The following is a description of a gene set: from publication Gryder BE, Yohe ME, Chou HC, Zhang X, Marques J, Wachtel M, Schaefer B, Sen N, Song Y, Gualtieri A, Pomella S, Rota R, Cleveland A, Wen X, Sindiri S, Wei JS, Barr FG, Das S, Andresson T, Guha R, Lal-Nag M, Ferrer M, Shern JF, Zhao K, Thomas CJ, Khan J (PMID 28446439) Human Gene Set: GRYDER_PAX3FOXO1_TOP_ENHANCERS While previous studies have attempted to identify PAX3-FOXO1 target genes, these were based either on changes in gene expression or proximity to PAX3-FOXO1 in a single cell line with no consideration of expression or chromatin context. By gene expression many targets could be falsely identified which were in fact indirect, and 336 (31%) of the nearby genes previously reported to be direct targets were not expressed, while others may not be physically interacting because of barriers in 3D chromatin space. We therefore identified high-confidence PAX3-FOXO1 target genes by a series of criteria: first, using only PAX3-FOXO1 bound to enhancers recurrent in cell lines and tumors. Secondly, we only selected expressed genes, as PAX3-FOXO1 was not found in repressive chromatin. Third, we excluded nearby expressed genes if they were not found within the same topologically associated domain (TAD) as the PAX3-FOXO1 bound enhancer. Fourth, we also called out the maximally expressed gene within each TAD harboring PAX3-FOXO1. This approach removed 435 nearby but not expressed genes, and 78 expressed but out of TAD bounds. We found 1010 high-confidence targets, 678 of which were novel, and 439 were significantly reduced by shRNA knockdown of PAX3-FOXO1 for 48 hours. Novel targets include 24 oncogenes, 14 pan-cancer upregulated genes, 53 transcription factors, and 7 imprinted genes, many of which were rapidly decommissioned upon depletion of P3F (both reduced RNA-seq and H3K27ac at their enhancers. Expressed genes (FPKM>1) associated with super-high-confidence PAX3-FOXO1 sites with highly-recurrent enhancers in primary tumors and cell lines, restricted to those within topological domain boundaries species: Homo sapiens, and this is the list of marker genes: HSPG2 (NCBI Gene Id 7796), PRDM12, PODXL2, RPS6KC1, ZNF664, NDUFA12, ZNF331, SPSB4, BABAM1, TRIM45, CDC5L, ASS1, ATP6V1E1, TCF7L2, FIP1L1, PGF, STIM2, SEMA6A, ARHGEF10, PARN, ARHGAP26, SHB, ASB13, TNKS2, PIPOX, RAD51C, NCOA1, LRRC10B, TRAP1, ERICH1, TMCC3, ATF6, CLINT1, TTK, JARID2, PSMD8, RERE, ITGB1, NRG1, GNAS, RCN1, COX5A, TTI1, NOTCH2, PARK7, FSCN1, TFAP2B, SPRY1, PPP1R3B, HS1BP3, CSTF2T, LRPAP1, EXTL3, CTNNBL1, FUT10, HNRNPK, TGOLN2, ARL4C, INPP4B, TBX15, SDC2, FASTKD2, DDX1, TBCD, SETX, GIT2, SFXN1, MEDAG, GRB10, MLH1, RMI1, TCF12, SLC38A10, PROX1, PEMT, PNO1, PEBP1, SCARB1, GDI2, HMGXB4, RNF216, PSMB6, PCBD1, YWHAZ, EFHD2, CHST11, TCF7L1, TSC22D2, CELF2 (CUGBP Elav-like family member 2), GALNT11, DDOST, MEST, TXNRD1, GART, ACTB, TLE3, AP1B1, TNPO1, ACTG1, PTPN12, GNL3L, ALK, PARP1, VDAC3, UQCR10, RNF145, STX16, RBPJ, LAMB3, IMMT, RNF114, CPA5, DCP2, COBL (cordon-bleu WH2 repeat protein), LAPTM4A, CEBPZ, VPS4B, MAGED2, GLO1, NR3C1, MSH6, CLASP1, FBXO21, UBE2G1, ADCY9, PARD3, ACOX3 (acyl-CoA oxidase 3, pristanoyl), BCAR3, POMT2, TANK, RBM38, PRCP, NACA, ANLN, IL4R, AGPAT5, NOSIP (NCBI Gene Id 51070), SNRPD3, MAGI1, PLAAT1, N4BP2L2, IGFBPL1, CCDC3, TBC1D2B, ANKRD13A, SF3A3, ELP1, UBAC2, SAMD4A, CDK2AP1, NSMCE1, BMERB1 (bMERB domain containing 1), ESYT2, CADM2, KANK4, HDAC5, PTTG1IP, TBCA, TMEM177, FAM136A, VAX2, KANK1, CDC42EP3, PFDN4, TEX261, DMRT2, ZIM2, STK24, TOM1, PKNOX2, AOPEP, GSE1, SSU72, MRPL23, ATP5MJ, TNNT2, RRM2B, APLF, GAS1 (NCBI Gene Id 2619), WDR45B, PPM1H, COA6, RAPGEF1, SLC38A1, RAD23B, CAP1, MSI2, GDAP1, SMPDL3A, CEP128, RNF181, CDON, FOXN2, CD9, RIMKLB, RAD51B, CGRRF1, GRN, ZNF264, KCTD2, NDUFS3, NDUFAB1, OLIG2, ECT2, TMBIM4, SDC1, CAND1, TUT7, ITPKB, ARHGEF3, ALDH1A3 (aldehyde dehydrogenase 1 family member A3), PEG3, CNOT2, POR, ZEB2, DDB1 (NCBI Gene Id 1642), ATOH8, IDH3A, OLFML2B, CHSY1, NUP160, LRIG1, GMPR, HACL1, TRAM2, HDHD5, VIPR2, CHD6, DPH5, MRS2, RSL1D1, RBMS1, TPX2, MCM2, BBIP1, APBB2 (amyloid beta precursor protein binding family B member 2), SULF2, MDH2, MYO9B, GINS2, PALD1, SCFD2, DAPK1, RAPH1, HSPH1, GPR89B, COL4A1, GNG11, MAN1C1, ENAH, CA11, IL17RD (NCBI Gene Id 54756), FGGY, LIMCH1, ERLIN2, ADAM10, IGF2, UQCRC2, MYO18B, YIPF5, PSD3, MPHOSPH9, MON2, OSBPL2 (oxysterol binding protein like 2), POLR2D, THAP1, TENT5A, BCOR, PINX1, ERRFI1, CREBBP, APPL1, MIF, DBT, BTAF1, MFSD2A, ZNF217, APP, RASSF4, SKA2, TOP2A, ZFP36L1 (NCBI Gene Id 677), ATF3, SUMO2, WSCD1 (WSC domain containing 1), SIK1, ADAM19, ADAMTS14, R3HDM2, TBL1XR1, SELENON, ALOX5AP, WDR43, MTREX, CASP9 (NCBI Gene Id 842), COPA, ECI2, MED13L, DTD1, DNTTIP2, CDC123, PEG10, IER5, HAUS1, SNTB1, FYN, BRCA2, SNX29, MYLIP, RRAGA, XRN1, LEPROTL1, PLXNA2, USP15, USP1, HECTD2, PRKG1, EEF2K, TNS3, CHD7, RBBP8, SETD7, SACS, EWSR1, MCC, GPR107, TSHZ3, MAT2A, QKI, COPS3, AUTS2, DPF1, ARK2N, ARPC2, SOX4, NCAPG2, BFAR, CYRIA, SASH1, NAA20, GGA2, PKP1, TSPAN7, SNX9, TLE1, RRAGC, NCOR2, STOML1, VASH2, PGS1, CGNL1, MCM3, GBF1, MN1, ZDHHC6, PTCD2, UCHL1, RBM20, ERI1, EIF3B, CDK14, GALNT17, ZZEF1, RBFOX1, MAN1A2, ITSN2, ATF7IP, KCNS3, DPY19L3, GALNT2, RASA3, ATP9B, SPATS2L, FAT1, WIPI2, CABLES1, MAP3K2, PDHB, OPA1, ZNG1A, CSRP1, NFIB, SUDS3, SERP1, COMMD10, NXT1, MNAT1, CHCHD3, FAM83D, COX7A2L, ELMO1, OS9, ACYP1, TMEM131L, MYCN, ZNF330 (zinc finger protein 330), NDUFS1, M6PR, UBE2G2, SLIRP (NCBI Gene Id 81892), SRP9, MYOD1, SARS1, RPL23A, ST6GAL2, RRP1B, VTI1A, KIAA1614, SLC38A6, MCFD2, UBL7, PREX1, SDE2, MRPL20, PON2, EYA2, SLC38A2, OAT, DARS1, SLC7A1, STARD13, INKA2, SLC38A9, FAM174A, PGBD5, NOLC1, PDZRN3, VANGL2 (NCBI Gene Id 57216), PODXL (NCBI Gene Id 5420), HELB, PXDN, RHOQ, LRRFIP2, PFN2, HP1BP3, BTD, CHST15, BCL2, ACTR8, KREMEN1, SLC24A3